Given this list of marker genes Mapk11, Stk11, Hyal1, Mme, Cdkn1a, Mfap4, Hyal3, Mapk14, Hyal2, Nlrp1a, Nlrp1b, Crip1, Map3k20, here is a description of the gene set: Mouse Gene Set: GOBP_CELLULAR_RESPONSE_TO_UV_B studied in species Mus musculus Any process that results in a change in state or activity of a cell (in terms of movement, secretion, enzyme production, gene expression, etc.) as a result of a UV-B radiation stimulus. UV-B radiation (UV-B light) spans the wavelengths 280 to 315 nm.